The following is a description of a gene set: species: Homo sapiens The early stages of human lymphopoiesis are poorly characterized. Here, we compared the lymphoid potential of a novel umbilical cord blood CD34(+)CD45RA(hi)CD7(+) hematopoietic progenitor cell (HPC) population with that of CD34(+)CD45RA(hi)Lin(-)CD10(+) HPCs, previously proposed as candidate common lymphoid progenitors. Limiting-dilution and clonal analysis, fetal thymic organ cultures, and culture onto Notch ligand Delta-like-1-expressing OP9 cells, showed that although CD34(+)CD45RA(hi)CD7(+) HPCs could generate cells of the 3 lymphoid lineages, their potential was skewed toward the T/natural killer (T/NK) lineages. In contrast, CD34(+)CD45RA(hi)Lin(-)CD10(+) HPCs predominantly exhibited a B-cell potential. Gene expression profiling with DNA microarrays confirmed that CD34(+)CD45RA(hi)CD7(+) HPCs selectively expressed T-lymphoid and NK lineage-committed genes while retaining expression of genes affiliated to the granulomonocytic lineage, whereas CD34(+)CD45RA(hi)Lin(-)CD10(+) HPCs displayed a typical pro-B-cell transcription profile and essentially lacked genes unrelated to the B lineage. In addition, both populations could be generated in vitro from CD34(+)CD45RA(int)CD7(-) and CD34(+)CD45RA(hi)Lin(-) HPCs with mixed lymphomyeloid potential, from which they emerged independently with different growth/differentiation factor requirements. These findings indicate that CD34(+)CD45RA(hi)CD7(+) and CD34(+)CD45RA(hi)Lin(-)CD10(+) HPCs correspond to multipotent early lymphoid progenitors polarized toward either the T/NK or B lineage, respectively. Human Gene Set: HADDAD_T_LYMPHOCYTE_AND_NK_PROGENITOR_DN from publication Haddad R, Guardiola P, Izac B, Thibault C, Radich J, Delezoide AL, Baillou C, Lemoine FM, Gluckman JC, Pflumio F, Canque B (PMID 15331438) Genes down-regulated in hematopoietic progenitor cells (HPC) of T lymphocyte and NK (natural killer) lineage., and this is the list of marker genes: ELANE, HCK, VCAN, IRF8, SCN3A, CD24, RRM2, MME, NRXN2, ACSL4, NPTX2 (NCBI Gene Id 95714), TRGC1, S100A8, JCHAIN, VPREB1, AZU1, CDC20, LYZ, CRIP1, KIF15, CSTA, MPO, F13A1, BLNK, ZWINT, ITGB7, RAB31, MS4A3, CST7, PALLD, HGF (hepatocyte growth factor), IL6R, ARHGEF10, TRIB2, PRTN3, DNTT, LEF1, TYROBP, HAL, CEBPD (CCAAT enhancer binding protein delta), MCM4, CSF1R, PLEK, GPR183, SLC2A5, TSPOAP1, LGALS1, G0S2, TNF, CCR9, LGMN, SERPINF1 (serpin family F member 1), LY86, CCL3, MS4A6A, CFD, IL7R, TRAF4, CD7, CCR7, SPON1, CTSG, LTB, RNASE6